Given this list of marker genes Adk, Parp1, Hand2, Hamp2, Edn1, Hamp, Pin1rt1, Adcy10, Pde9a, Adrb1, Mef2c, Camk2d, Prkca, Bmp10, Sirt1, Nr3c1, Fdps, Ddx39b, Ptk2, Mtpn, Rock1, Mtor, Pin1, Slc9a1, Ccn4, Adra1a, Slc25a4, Ep300, Parp2, Rock2, Mymk, Cdk9, Mef2a, Pde5a, Trpc3, Gsn, Agt, Twf1, Becn1, Trip10, Akap6, Nr4a3, Igf1, Nfatc3, Ece1, Ppp3ca, here is a description of the gene set: Any process that activates or increases the frequency, rate or extent of muscle hypertrophy. Mouse Gene Set: GOBP_POSITIVE_REGULATION_OF_MUSCLE_HYPERTROPHY species: Mus musculus